Given this list of marker genes VPS13B, STK39, CHMP4B, ALDH1A1, GCNT2, MIP, FOXC1 (forkhead box C1), APBB2, here is a description of the gene set: A homeostatic process in which the lens is maintained in a highly refractive, transparent state to allow for optimal focusing of light on the retina. Human Gene Set: GOBP_MAINTENANCE_OF_LENS_TRANSPARENCY studied in species Homo sapiens